The following is a description of a gene set: Genes down-regulated in comparison of naive follicular B cells versus early germinal center (GC) B cells. Upon immunization with a T cell dependent antigen naive follicular B cells (Fo) are activated and a germinal center reaction is induced. Within the next 2 weeks large germinal centers develop where the process of affinity maturation takes place. To analyze the gene expression profile of resting and activated B cells, follicular B cells (Fo), B cells from early (GC1) and late germinal centers (GC2) were isolated and their gene expression profile compared. Human Gene Set: GSE28237_FOLLICULAR_VS_EARLY_GC_BCELL_DN from publication Wilke G, Steinhauser G, Grün J, Berek C (PMID 20518031) studied in species Homo sapiens, and this is the list of marker genes: NMT1, CAP2, HSPD1, SDCBP, NSDHL, DYNLT1, PSAT1, SPRY3, ASPM, SAMM50, STC2, DMP1, ATP4B, DUOX1, NLRP14, PCLAF, PABPC1, PUM3, CCNF, API5 (apoptosis inhibitor 5), DRC12, E2F8, KCNK4 (NCBI Gene Id 50801), KIF14, DCTPP1 (NCBI Gene Id 79077), VAMP3, OSBP, NUDT2, STXBP1, NUP205, HDGF, RELN, SLC25A6, ADSS2, AGPS, ZWILCH, ANP32E, CDA, RSL24D1, RABGGTB, SNHG3, AARS1, PRDM4, KPNA2, CASP3 (caspase 3), EEF1AKMT2, PBK, AK3, PTPN11, NUP107, CAMK2N2, RHOH, TNKS2, SMU1, RPS3A, TCERG1, PSPH, DDX21, ECHDC1, EIF3B, FUT1, CCNE2, SLC25A14, MARVELD2, UBASH3A, NBN, CPNE2, DNAJA2, CENPP, DEK, SEPTIN7, ZFPM2, MTHFD1L, TRMT9B, RERE, DESI2 (desumoylating isopeptidase 2), RRAGC (Ras related GTP binding C), CORO7, ARL6IP4, ARVCF, IPP, FZD5, CDC16, DYNLT2, CASP8, DFFB, F2RL1, ECT2, ATP1B3, CHEK1, CDCA7L, KCNK6, TBL1XR1, TECTB, CEP55 (NCBI Gene Id 94765), STRN3, PGM2, GALNT2, RBMXL1, CCM2, TRIM37, SHMT1, HMGB2, ATP2A2, SSR3, RUVBL1, CCT7, KIF20B, LAMP1, CNOT9, RAB2A, MRPL16, NDUFAB1, NOP58, ARPC5, HRH1, TOP2B, DIRAS1, GADL1, ACO2, RNF19A, CDC5L, AGPAT5, GET1, PSMD12, COPS4, OPLAH, NSA2, NCOA4, GSTA5, NUDC, PTGR1, TCP1, YWHAB, SRSF11, LRRC59, VOPP1, METRN, PPT2, SERHL2, ISYNA1, GPR150, FABP5, UBR7, CLP1, NUP50, CENPA, ENOPH1, NGLY1, CEP19, CHRNA7, CDC6, SLPI, SPO11, FXR1, C21orf91, CD44, CUL1, DHRS1, HSCB, CDCA5, IL22RA2, TNFAIP8L1, TUBA1B, INTS9, ZFAND5, EIF5A, CDC123, JAKMIP2, ATL2, RGS10, MCM7, MRPS9, EOLA1 (NCBI Gene Id 91966), BRD8, OTUB2, KHDC3L, PDE3B, HTR7, ERCC3, ATP5PB, BCAS2, RPS6KB1, COPZ2, POLE3, PRR11, SS18L1, MTMR2, ACACA, SUCLG2, CRELD2, WDR46, SMOC1, DCAF12L1, ZRANB3, AP3S1, SFT2D2, GLOD4, SLC7A3, ARCN1